The following is a description of a gene set: Genes up-regulated in EpiSC cells (mouse epiblast embryonic stem cells) after treatment with the ALK inhibitor SB-431542. studied in species Mus musculus The application of human embryonic stem (ES) cells in medicine and biology has an inherent reliance on understanding the starting cell population. Human ES cells differ from mouse ES cells and the specific embryonic origin of both cell types is unclear. Previous work suggested that mouse ES cells could only be obtained from the embryo before implantation in the uterus. Here we show that cell lines can be derived from the epiblast, a tissue of the post-implantation embryo that generates the embryo proper. These cells, which we refer to as EpiSCs (post-implantation epiblast-derived stem cells), express transcription factors known to regulate pluripotency, maintain their genomic integrity, and robustly differentiate into the major somatic cell types as well as primordial germ cells. The EpiSC lines are distinct from mouse ES cells in their epigenetic state and the signals controlling their differentiation. Furthermore, EpiSC and human ES cells share patterns of gene expression and signalling responses that normally function in the epiblast. These results show that epiblast cells can be maintained as stable cell lines and interrogated to understand how pluripotent cells generate distinct fates during early development. from publication Tesar PJ, Chenoweth JG, Brook FA, Davies TJ, Evans EP, Mack DL, Gardner RL, McKay RD (PMID 17597760) Mouse Gene Set: TESAR_ALK_TARGETS_EPISC_3D_UP, and this is the list of marker genes: Tubb3 (tubulin, beta 3 class III), Gbx2, Msx1, Dcx, Sox1, Zic1, Nes